Given this list of marker genes FOXO1, SLITRK3, PECAM1, ZNF350, GABBR1, WWC3, ACE2, FCER1A, DBNDD1, IL4R, MAOB, CHML, HEBP1, SLC6A8, TRDMT1, BCL7A, CORO2B, PEG10, XYLT1, GTF3C4, NEIL1 (NCBI Gene Id 79661), RFC1, C6orf120, MGAM, CHAT, IGHM, MITF, OSBP, CLPS, TCL1A, UGDH, ANXA9, ZNF304, IRS2, NR1H3, BST1, TBC1D13, CXCR4, EPHA3, MFAP5, ZNF135, ACVR2B-AS1, DCLK2, SH3BP2, SMUG1, UXS1, DSP, NKX3-1, BACH2, MYO15B, FAM8A1 (NCBI Gene Id 51439), ATP6V0A1, LDOC1, ZNF112, LARGE1, GCNT1, SCN3A, TJAP1, PLEKHA1, CCDC181, LRCH1, SKAP1, TPST1, SLC2A2, IL21R, AQP9, AOX1, RAB15, CR2, PBX3, TENT5A, AGO4, TSPAN13, EXOG, SLC12A6, ZNF43, OBSCN, ZNF492, KLF9, PSMC3IP, LRRC23, SLA, DSTYK, CACNG4, SIX3, APLP2, IAPP, NCK2, SLC35E2A, SLC39A4, PCDH8, ZBTB16, H2AC6, MMP17, DIRAS3, DTX4, P2RY14, SIAH2, HYAL1, IL1RAPL2, RGL2, DPPA4, ZNF318, SV2C, IFNGR1, NR3C2, SERPINB9, LYST, MARCHF3, TAAR2, LAMC1, POLR3C, EHD4, ACBD4, ABHD4, PCDH9, MTMR9, VPS72, TRAPPC14, ST18, AMT, RAPGEF6, KLHL35, SPRY4, SORL1, MAGEB1, DGKD, SOBP, DGCR11, TTC28, IGHD, OSM, FMO5, GPRASP1, PER1, DNASE1L3, LAIR1, ZNF280A, ABCB4, P2RX1, ZNF37BP, SPTSSA, DIO1, SOX18, ZNF235, SZT2, KCTD20, SATB1, APOOL, DDR1, CCP110, DPYD, TPMT, FCER2, PHC1, DIS3, UGT8, INTS9, CD72, FAM53B, TREML2, NIPBL, CEMIP2, CHMP2B, ZNF136, MYEF2, PRCP, PPFIBP1, SMURF1, BTG1, SESN1, PAIP2B, TPCN1, NPY, WNT6, OLFML2A, SLC30A4, SYT13, ADARB1 (adenosine deaminase RNA specific B1, NCBI Gene Id 104), F2, ZNF682, TYR, MMP2, WBP4, SMAD3, INTS6, GALNT3, KMO, VAV3, AFF4, GRK4, ZNF124, CD22, ZNF571, CYP2A7P1, DHX34, YBX3, SMR3B, here is a description of the gene set: Human Gene Set: GSE22886_NAIVE_VS_IGG_IGA_MEMORY_BCELL_UP Genes up-regulated in comparison of naive B cells versus memory IgG IgA B cells. Immune cell-specific expression is one indication of the importance of a gene's role in the immune response. In order to identify such patterns, we set out to broadly profile gene expression in a variety of immune cells. from publication Abbas AR, Baldwin D, Ma Y, Ouyang W, Gurney A, Martin F, Fong S, van Lookeren Campagne M, Godowski P, Williams PM, Chan AC, Clark HF (PMID 15789058) studied in species Homo sapiens